The following is a description of a gene set: Mouse Gene Set: MIR_7235_5P species: Mus musculus Genes predicted to be targets of miRBase v22 microRNA mmu_miR_7235_5p in miRDB v6.0 with MirTarget v4 prediction scores > 80 (high confidence targets). from publication Chen Y, Wang X (PMID 31504780), and this is the list of marker genes: Ptprn, Serpine1, Atp1a3, Arf3, Atp1b2, Cux2, Prdm2, Haus5, Mip, Wdtc1, Mapre1, Pak3, Lrrc7, Septin3, Dhx40, Kansl1, Focad, Tbc1d22b, Aoc3, Mucl2, Nr2c1, 6430548M08Rik, Shisa6, Igf2bp2, Zfp395, Rho, Mycl, Itsn1, Rnf152, Galnt17, Bsn, Nectin1, Sytl4, Ankrd63, Tbcel, Tfdp2, Htt, Lax1, Fam171a1, Chd3, Ppbp, Dusp23, Shmt2, Kpna6, Lhx2, Prelp, Scrn3, St3gal1, Fgfr1, Zfp26, Zc3hav1l, Lurap1, Nfat5, Hnrnpll, Thsd7a, Slc4a8, Setd7, Pianp (PILR alpha associated neural protein), Banf1, Aqp6, Plxna4, Tmem9, Wiz, Zfp64, Nup205, Mul1, Crp, Nbl1, Got2, Nnat, Rab5b, Prickle2, Taok3, Fmo5, Srp54b, Jazf1, Cnot6, Ap1s3, Gadd45gip1, Mdga2, Fgf10, Slc7a1, Gas7, B3gat2, Ccdc32, Chst1, Astn2, Lpar2, Eif4b, Klhl20, Rbm20, Eya3, Erv3, Frmd5, Msi2, Trim58, Hdgf, Vti1a, Rprd2, Npnt, Otof, Psmg2, Klk4, Flrt2, Rpgr, Srp54c, Nedd4l, Tmem104, D2hgdh, Sash1, Ifi203, Limd2, Pakap, Zfpl1, Il17re, Syp, Eif4e1b, Mecp2, Cyyr1 (NCBI Gene Id 224405), Iffo2, Frs2, Nkain2, Matcap1, Slc25a23 (solute carrier family 25 (mitochondrial carrier; phosphate carrier), member 23), Fbxw8, Ldlrad3, Slc9a8, Kcnj10, Dusp16, Tppp, Zbtb34, Bard1, Sh3gl2, Dnajb2 (NCBI Gene Id 76593), Naa60, Dcaf17, Rgs20, AI837181, Dtx4, Naga, Gnat1, Syn3, Epb41l4a, Rpp40, Grip1, Atxn1, Samhd1, Synj2bp, Wnt4, Gabrg2, Dnal1, Ndufa2, Rsl24d1